Given this list of marker genes TGFBR2, ZBTB16, PRDM1, AP3D1, AP3B1, ZNF683, here is a description of the gene set: studied in species Homo sapiens Any process that modulates the frequency, rate or extent of natural killer T cell differentiation. Human Gene Set: GOBP_REGULATION_OF_NK_T_CELL_DIFFERENTIATION